The following is a description of a gene set: Human Gene Set: GOBP_REGULATION_OF_MITOCHONDRIAL_TRANSCRIPTION studied in species Homo sapiens Any process that modulates the frequency, rate or extent of transcription occurring in the mitochondrion., and this is the list of marker genes: CHCHD10, KANSL3, KAT8, THAP11, METTL4, KANSL1, PRKAA1, TEFM, MTRES1